Given this list of marker genes Gng10, Kcnj12, Kcnj10, Gabbr1, Kcnj3, Gng5, Gnb3 (guanine nucleotide binding protein (G protein), beta 3), Kcnj2, Gng11, Gng3, Gng7, Kcnj5 (NCBI Gene Id 16521), Gngt1, Gnb5, Gng8, Gng4, Gnb2, Gngt2, here is a description of the gene set: part of: Inwardly rectifying K+ channels Reactome Pathway: G protein gated Potassium channels electronically inferred by orthology from the curated human pathway studied in species Mus musculus This event has been computationally inferred from an event that has been demonstrated in another species.<p>The inference is based on the homology mapping from PANTHER. Briefly, reactions for which all involved PhysicalEntities (in input, output and catalyst) have a mapped orthologue/paralogue (for complexes at least 75% of components must have a mapping) are inferred to the other species.